The following is a description of a gene set: species: Mus musculus This event has been computationally inferred from an event that has been demonstrated in another species.<p>The inference is based on the homology mapping from PANTHER. Briefly, reactions for which all involved PhysicalEntities (in input, output and catalyst) have a mapped orthologue/paralogue (for complexes at least 75% of components must have a mapping) are inferred to the other species. Reactome Pathway: Phosphate bond hydrolysis by NUDT proteins part of: Purine catabolism electronically inferred by orthology from the curated human pathway, and this is the list of marker genes: Nudt18, Nudt9, Nudt15, Adprm, Nudt5, Nudt1, Nudt16